The following is a description of a gene set: part of: Platelet Aggregation (Plug Formation) electronically inferred by orthology from the curated human pathway species: Mus musculus This event has been computationally inferred from an event that has been demonstrated in another species.<p>The inference is based on the homology mapping from PANTHER. Briefly, reactions for which all involved PhysicalEntities (in input, output and catalyst) have a mapped orthologue/paralogue (for complexes at least 75% of components must have a mapping) are inferred to the other species. Reactome Pathway: Adrenaline signalling through Alpha-2 adrenergic receptor, and this is the list of marker genes: Adra2b, Adra2a, Adra2c